The following is a description of a gene set: studied in species Mus musculus Transport of a vesicle from the plasma membrane to the endosome. Mouse Gene Set: GOBP_PLASMA_MEMBRANE_TO_ENDOSOME_TRANSPORT, and this is the list of marker genes: Commd1, Sort1 (NCBI Gene Id 99747), Usp6nl, Grin2a, Rab5b, Sgsm3, Rab35, Tbc1d21, Rab5c